The following is a description of a gene set: species: Homo sapiens The development, homeostasis and function of B lymphocytes involve multiple rounds of B cell receptor (BCR)-controlled proliferation and prolonged maintenance. We analyzed the role of transcription factor Zfx, a recently identified regulator of stem cell maintenance, in B cell development and homeostasis. Conditional Zfx deletion in the bone marrow blocked B cell development at the pre-BCR selection checkpoint. Zfx deficiency in peripheral B cells caused impaired generation of the B-1 cell lineage, accelerated B cell turnover, depletion of mature recirculating cells, and delayed T-dependent antibody responses. Zfx-deficient B cells showed normal proximal BCR signaling, but impaired BCR-induced proliferation and survival. This was accompanied by aberrantly enhanced and prolonged integrated stress response, and delayed induction of Cyclin D2 and Bcl-xL proteins. Thus, Zfx restrains the stress response and couples antigen receptor signaling to B cell expansion and maintenance during development and peripheral homeostasis. Genes up-regulated in B lymphocytes stimulated by anti-IgM for 12h: wildtype versus ZFX knockout. from publication Arenzana TL, Smith-Raska MR, Reizis B (PMID 19329779) Human Gene Set: GSE13547_WT_VS_ZFX_KO_BCELL_ANTI_IGM_STIM_12H_UP, and this is the list of marker genes: WDFY3, SHROOM4, MIR181D, RXFP3, NES (NCBI Gene Id 79662, nestin), MIR665, PGF, CABP2, VWA5B2, FOXI1, EFHC1 (NCBI Gene Id 94915), CYP46A1, EFNB1, BSN, PIK3R6, FBLL1, RBM24, SSPOP, SYDE2, ASPDH, COL4A1, TTC9B, HTRA3, EFNB3, TACR2, CKM, KLHL31, IFNE, MYT1, CHRM1, TCAF2, FAM117A, SRF, SSTR3, CASKIN1, RIMS4, PTPRT, PISD, MEGF6, CALCR, DCAF12L2, DACH1, CEACAM16, FAM222A, GGNBP1, DRAM1, SOD3 (superoxide dismutase 3), PCDH17, RFX2, COL5A1, EDN3, PIWIL1, GPR63, SCYL1, BEST2, PGPEP1, GABRA6, LHFPL2, TSKS, MIR138-2, CRISPLD1, UCN2, MRGPRG, TEAD3, ADAM15, GPR25, TCAM1P, MC5R, RGS20, SPHK1, H2BC21, CHGA, MIR346, RHBDD3 (rhomboid domain containing 3), PTH2, TTYH1, TCF7L1, ESRRA, ZDHHC22, LRRN4, PIPOX, FOLR2 (folate receptor beta), HES7, GJC3, TMEM120B, OSBP2, GGN, PCDHB17P, ITGA11, KISS1R, SYCN, CCR4, WDR72, HHAT, SORD, EVC2, KCNK9, DUOX1, GATA4, SYNDIG1, GBX1, PGA5, SRC, SCGB3A1, PWWP3B, SEC14L2, PITX3, PRIMA1, ARHGEF28, TOP2A, APLN, MMP25, L1TD1, NECTIN1, MIR93, SIX5, DRGX, P2RX1, HGFAC, NPHP3, TCERG1L, ZP1, TMEM210, TTYH2, CHRNA5, MX2, CCNB1IP1, CCKBR (NCBI Gene Id 887), RASA4, CLEC4G, ENPEP, WFDC11, GAS2L2, KCNJ6, ADGRG7, ADRB1, ST3GAL5, KCNJ9, NHERF4, GPR20, BCAM, ANKS6, SLC29A4, KRTAP4-7, PRSS33 (NCBI Gene Id 260429), SYT7, WFIKKN1